The following is a description of a gene set: Any process that activates or increases the frequency, rate or extent of telomere maintenance via telomere lengthening. species: Homo sapiens Human Gene Set: GOBP_POSITIVE_REGULATION_OF_TELOMERE_MAINTENANCE_VIA_TELOMERE_LENGTHENING, and this is the list of marker genes: HNRNPD, CCT3, DKC1, TCP1 (t-complex 1), CCT4, PARN, ATM, HSP90AA1, PTGES3, CCT8, RTEL1, POT1, TNKS2, CCT6A (NCBI Gene Id 908), CCT7, FBXO4, HNRNPA1, CCT5, DHX36, ATR, CCT2 (NCBI Gene Id 10576), WRAP53, HNRNPA2B1, CTNNB1, NAF1, TNKS